The following is a description of a gene set: part of: Downstream signaling of activated FGFR1 Reactome Pathway: PI-3K cascade:FGFR1 species: Mus musculus This event has been computationally inferred from an event that has been demonstrated in another species.<p>The inference is based on the homology mapping from PANTHER. Briefly, reactions for which all involved PhysicalEntities (in input, output and catalyst) have a mapped orthologue/paralogue (for complexes at least 75% of components must have a mapping) are inferred to the other species. electronically inferred by orthology from the curated human pathway, and this is the list of marker genes: Fgf1, Gab1, Fgfr1, Fgf6, Frs2, Fgf5, Fgf4, Grb2, Fgf10, Fgf22 (NCBI Gene Id 67112), Fgf23, Fgf2, Fgf20, Fgf8, Fgf17, Kl